Given this list of marker genes NR1H2, UBE2I, NR3C2, NR3C1, VDR, NR5A2, RARA, AR, NR1H4, RXRA, HDAC4, ESR1, PPARG, PIAS4, PPARA, NR2C1 (NCBI Gene Id 7181), THRB (NCBI Gene Id 7068), PIAS3, SUMO3, SUMO1, SUMO2, PIAS2, NR4A2, PGR, PIAS1, NR1I2, RORA, NR1H3, THRA, NR5A1, here is a description of the gene set: Human Gene Set: REACTOME_SUMOYLATION_OF_INTRACELLULAR_RECEPTORS SUMOylation of intracellular receptors studied in species Homo sapiens